Given this list of marker genes SNRPE, PLXDC1 (plexin domain containing 1), MAN2A1, PAN2, CDS2, RASSF8-AS1, PGAM2 (phosphoglycerate mutase 2), GAR1, NCAPD3, NR2C1, SEC31B, SEC24B-AS1, FYB1, ZNF655, RBM34, SETMAR, HIBCH, CDR1, ZNF667-AS1, MATCAP1 (NCBI Gene Id 654077), TIMM10 (NCBI Gene Id 26519), SEPTIN7P2, IFNA8, POLG2, POLE2, RACK1, C6orf120, VPS11, VPS33B, METTL16, DIP2B, TDRD12, ELP2, ZNF451, EPHX2, DNPEP, PPIL2, NAA16, NFYC-AS1, COL18A1-AS1, MSL3 (NCBI Gene Id 25867), NDUFB4, DDX39B, RBM20, SLC39A10, PRKCA (protein kinase C alpha), ASNSD1, KBTBD6, ZBTB40, FBF1, MMD, SLC25A15, ING2, ATP5MJ, SEPTIN1, EBLN2, MTURN, MDM1, COQ9 (NCBI Gene Id 57017), PIGP, ATP11C, MAL, RPL13A (NCBI Gene Id 94020), HAT1, HLA-DOB, MICU2, EPCIP-AS1, LARP7, DPEP3, R3HDM1, DDIAS, TMEM243, UXS1, HUWE1, STRIP1, CNPY3, FAM136A (family with sequence similarity 136 member A), SNPH, PDCD4-AS1, LRRC56, PPIEL, GCA, MAN1C1, COX7C, RAB30, DSC1, KLHL3, FBRSL1, GXYLT1, PRDX3, GATB, PHYH, ARGLU1, SFSWAP, VPS52, TBC1D23, ZBTB18, CERS6, USF1, RPL28, SECISBP2, IFT46, PSMD6, MIX23, TRABD2A, PPP6R3, ANAPC4, CEP85L, NXPE4, PPWD1, EAPP, LCAT, SCCPDH, EIF2S1, EIF3H, PVT1, DCUN1D5, WHAMM, C6orf62, BTF3L4, RPL38, LINC00339, E2F7, POLR1D, SNHG29, KAT5, RABL3, RPS23, TUBE1, ZNF789, DDI1 (NCBI Gene Id 414301), AGBL3, EMC3-AS1, CTBP1-AS, RPL39, RPS18, CD8B, MYH3, IL6ST, UHRF2, RPSA, KLRC4, TSNAXIP1, NPAS2, TIGD1, RPL27, NBEA, TTN (titin), MAP1B, NAXD, RPL31, MAPKAPK5-AS1, CLK2, CA6, DHX35, ETFRF1, LEF1-AS1, KLRK1, WRNIP1, KCNJ9, DZIP3, NOP10, PIGL, NELL2, COPS5, RAD51C, FDX2, ABCC1, UTP15, MEST, SRSF1, ARMCX1, BAZ1A, ZBED5, LRP5L, LCDR, COX4I1, RIPK4, SETD1B, SMIM27, MSH6, SDR39U1, PCF11, REG4, APOO, NR1H3, CLYBL, PDPR, FBXO11, FAM111A, HMG20B, ECRG4, ZNF805, PCSK5, FCGBP, NECAP1, here is a description of the gene set: from publication Schenk M, Krutzik SR, Sieling PA, Lee DJ, Teles RM, Ochoa MT, Komisopoulou E, Sarno EN, Rea TH, Graeber TG, Kim S, Cheng G, Modlin RL (PMID 22447076) human blood monocytes were isolated, activated and harvested at several timepoints In this study, we identified genes that were differentially expressed in human monocytes activated with eiter NOD2L and/or TLR2/1L. studied in species Homo sapiens Genes down-regulated in monocytes (24h): untreated versus M. tuberculosis 19 kDa lipopeptide. Human Gene Set: GSE34156_UNTREATED_VS_24H_TLR1_TLR2_LIGAND_TREATED_MONOCYTE_DN